The following is a description of a gene set: studied in species Homo sapiens The appearance of interleukin-1 alpha due to biosynthesis or secretion following a cellular stimulus, resulting in an increase in its intracellular or extracellular levels. Human Gene Set: GOBP_INTERLEUKIN_1_ALPHA_PRODUCTION, and this is the list of marker genes: S100A13, NLRP10, CX3CL1, IL16, MIR142, MIR181A2, MIR181C, CALCA, IL1R2, ISL1, P2RX7, PANX1